The following is a description of a gene set: studied in species Homo sapiens Human Gene Set: GOBP_KETONE_BIOSYNTHETIC_PROCESS The chemical reactions and pathways resulting in the formation of ketones, a class of organic compounds that contain the carbonyl group, CO, and in which the carbonyl group is bonded only to carbon atoms. The general formula for a ketone is RCOR, where R and R are alkyl or aryl groups., and this is the list of marker genes: SRD5A2, DKKL1, COQ3, BMP2, FDX2, UBIAD1, BMP5, CREB1, DAB2, CLCN2, PDSS2, INHBA, DGKQ, RTN4IP1, PRKG1, NDUFA9, EGR1, FSHB, BMP6, COQ8B, PDSS1 (decaprenyl diphosphate synthase subunit 1), LHB, WNT4, CYP11B1, SIRT6, GGCX, COQ6, HSD17B1, GPRC6A, FDXR, COQ7, SIRT5, TPI1, COQ5, COQ8A, COQ4, CYP11B2, PPTC7, ADM, REST, COQ2, CYP19A1, SCP2, STARD7, CACNA1H, COQ9, BGLAP, H6PD, DKK3, ADCK2, AKR1C3, STARD3, HSD17B3